The following is a description of a gene set: Caspase-5 (CASP5), an inflammatory caspase closely related to caspase-4, is involved in the innate immune response triggered by cytosolic lipopolysaccharide (LPS), a component of the outer membrane of Gram-negative bacteria (Shi J et al., 2014, 2015; reviewed by Eckhart L & Fischer H, 2024). CASP5 expression is low at baseline but strongly induced by pro-inflammatory stimuli such as LPS through TLR4-dependent NF-κB signaling (Lin XY et al., 2000; Eckhart L et al., 2006; Viganò E et al., 2015). In human peripheral blood mononuclear cells (PBMCs), LPS stimulation results in a >10-fold increase in CASP5 expression levels, a greater induction than that observed for CASP1 or CASP4 (Eckhart L et al., 2006). Similarly, CASP5 shows higher LPS-inducibility in human monocytes at both mRNA and protein levels compared to CASP4 (Viganò E et al., 2015; Cheng Y et al., 2023). Both interferon γ (IFNγ) and IFNα/β may contribute to CASP5 upregulation by activating JAK-STAT-dependent transcription (Lin XY et al., 2000; Eckhart L et al., 2006; Rooney M et al., 2024). Promoter analysis reveals conserved NF-κB and STAT binding motifs (Eckhart L et al., 2006), and expression is highest in immune-related tissues including blood, spleen, lung, and colon, as per GTEx data (Eckhart L & Fischer H 2024). CASP5, like CASP4, is activated when intracellular bacterial LPS binds to its N-terminal caspase activation and recruitment domain (CARD), promoting oligomerization and proximity-induced activation of CASP5 (Shi J et al., 2014). CASP5 undergoes autocatalytic cleavage at aspartate residues, yielding large and small subunits that assemble into the active CASP5 heterotetramer (Shi J et al., 2014; Viganò et al., 2015).<p> Activated CASP5 can then cleave gasdermin D (GSDMD), which is also a substrate of CASP1, CASP4, and Casp11, a murine homolog of human CASP4/CASP5 (Shi J et al., 2014, 2015; Kayagaki N et al., 2015; Zhao Y et al., 2018; Wang K et al., 2020). The resulting N-terminal fragment of GSDMD oligomerizes to form pores in the cell membrane, leading to pyroptosis in mammals (Liu X et al., 2016; Ding J et al., 2016; Sborgi L et al., 2016; Aglietti RA et al., 2016). CASP5 also processes pro-IL-18 and pro-IL-1β. Like CASP4, CASP5 efficiently cleaves pro-interleukin-18 (pro-IL-18) at aspartic acid residue D36 to generate its mature, biologically active form (Shi X et al., 2023; Devant P et al., 2023; Exconde PM et al., 2023; reviewed by Exconde PM, 2024). Structural and biochemical analyses revealed that this cleavage relies on a bivalent recognition mechanism, in which pro-IL-18 binds CASP4/CASP5 through two interfaces: the protease exosite binds a hydrophobic pocket within pro-IL-18, while the active site of caspase engages charged residues located within and adjacent to the tetrapeptide recognition motif in the pro-domain (Shi X et al., 2023; Devant P et al., 2023). In contrast, CASP5- and CASP4-mediated cleavage of pro-IL-1β at D27 produces an inactive fragment that lacks receptor-stimulating activity (Exconde PM et al., 2023; reviewed by Exconde PM, 2024).<p>Cytosolic delivery of LPS can occur via endocytosis of outer membrane vesicles (OMVs) released by Gram-negative bacteria (Wacker MA et al., 2017; Bitto NJ et al., 2018; reviewed in Barker JH and Weiss JP, 2019; Page MJ et al., 2022), or through phagolysosomal rupture following bacterial uptake. Guanylate-binding protein 1 (GBP1) directly binds LPS on cytosol-exposed bacteria and, along with other GBPs (GBP2, GBP3 and GBP4, forms a coat on the bacterial surface, creating a platform that recruits CASP4 to facilitate inflammasome activation (Santos JC et al., 2020; Wandel MP et al., 2020). While CASP5 likely follows a similar GBP-mediated recruitment mechanism, there is currently no direct evidence for a physical interaction between CASP5 and GBPs, and this interaction is therefore not shown here. part of: Non-canonical inflammasome activation Reactome Pathway: CASP5 inflammasome assembly studied in species Homo sapiens, and this is the list of marker genes: CASP5